Given this list of marker genes MIR2110, PDCD4, SORCS3, XIAPP1, CASP7, SLC18A2-AS1, SMC3, CFAP58, ENSG00000304538, ENSG00000286289, GFRA1, LINC02627, CFAP43, RN7SKP278, MIR548E, RPL13AP6, RNU4-5P, RNA5SP325, DUSP5-DT, HSPA12A, RPS15AP30, AURKAP2, MIR3663HG, RPL21P91, UBE2V1P5, RNA5SP327, LINC02661, FHIP2A, RNU7-165P, AFAP1L2, MXI1, YWHAZP5, RPL12P26 (NCBI Gene Id 100271404), VTI1A, CCDC172, GSTO1, DUSP5, MIR936, CFAP58-DT, PNLIPRP1, RNU6-1121P, SHOC2, ENSG00000294147, MIR609, PPIAP39, MIR4483, PLEKHS1, RNU5B-6P, MIR4295, ITPRIP-AS1, NHLRC2, SPMIP5, LINC02620, VWA2, BTBD7P2, SORCS3-AS1, ABLIM1 (actin binding LIM protein 1), PPIAP38, SFR1, ADRB1, ENSG00000297231 (novel transcript), ITPRIP, RN7SL384P, MIR3663, HMGB3P5, SMNDC1, LINC02626, RPL5P27, ACSL5 (acyl-CoA synthetase long chain family member 5), ADRA2A, PDCD4-AS1, LINC02935, SNRPGP12, TCF7L2, SHTN1 (shootin 1), MIR6715A, MAPKAPK5P1, LINC01435, RNU6-709P, ADD3, GPAM, PPIAP19, ENSG00000285587, ENO4, RN7SKP288, ENSG00000237761, KCNK18, RBM20, XPNPEP1, ATRNL1, PTGES3P5, BTF3P15, MIR4680 (NCBI Gene Id 100616113), LINC02624, COL17A1, GSTO2, DCLRE1A, TECTB, ZDHHC6, HMGB3P8 (high mobility group box 3 pseudogene 8), ENSG00000212589, TRUB1, RPL15P13, HSPA12A-AS1, TAF9BP2, BBIP1, MIR4482, HABP2, PHB2P1 (NCBI Gene Id 650109), GUCY2GP, RPS6P15, SLC18A2, ENSG00000260917, RNU6-1090P, RNU6-463P, SNRPGP6, RPL7P35, PNLIP, PNLIPP1, PNLIPRP3, ADD3-AS1, RNA5SP326, RNU6-839P, PNLIPRP2, NRAP (nebulin related anchoring protein), NTAN1P1, VAX1, TDRD1, CCDC186, MIR6715B (microRNA 6715b), RPL23AP59, ENSG00000228484, SORCS1, here is a description of the gene set: Human Gene Set: chr10q25 species: Homo sapiens